Given this list of marker genes LAMTOR1, INHBA, LAMTOR2, BMP6, BMP2, LAMTOR5, SLC38A9, RRAGA, PSMC3IP, LAMTOR4, FNIP2, GNB5, LAMTOR3, RRAGC, PCNA, FLCN, here is a description of the gene set: Human Gene Set: GOCC_ENZYME_ACTIVATOR_COMPLEX studied in species Homo sapiens A protein complex capable of activating an enzyme. Activating subunits may dissociate from the catalytic unit before the enzyme is active.